The following is a description of a gene set: species: Mus musculus The chemical reactions and pathways resulting in the formation of chondroitin sulfate proteoglycans, which consist of a core protein linked to a chondroitin sulfate glycosaminoglycan. The chondroitin sulfate chain is composed of the repeating disaccharide unit beta-(1,4)-D-glucuronic acid-beta-(1,3)-N-acetyl-D-galactosamine, the latter of which can be O-sulfated. Chondroitin sulfate chains are covalently linked to serine/threonine residues (O-linked) of the core protein via a tetrasaccharide linker sequence (xylose-galactose-galactose-glucuronate). Mouse Gene Set: GOBP_CHONDROITIN_SULFATE_PROTEOGLYCAN_BIOSYNTHETIC_PROCESS, and this is the list of marker genes: Xylt2, B3gat1, Chsy3, Chpf2, B3gat3, Slc35b2, B3gat2, Chst3, Csgalnact1, Xylt1, Galnt3, B4galnt3, Csgalnact2, Chst12, Chpf, Chst7, Chsy1, Slc35d1, B4galnt4, Chst13, Pxylp1, Dse, Ugdh, B3galt6, Igf1 (insulin-like growth factor 1), Cytl1, Chst11